The following is a description of a gene set: studied in species Mus musculus Mouse Gene Set: GOBP_POSITIVE_REGULATION_BY_HOST_OF_VIRAL_GENOME_REPLICATION A process in which a host organism activates or increases the frequency, rate or extent of viral genome replication., and this is the list of marker genes: Pik3c3, Hspa8, Zfyve1, Ppib, Eef1a1, Vapb, Tbc1d20, Ythdc2, Stom, Nucks1, Vapa